Given this list of marker genes PSMB9, PSMA5, CD163, DYNLT1, STAC, GLRX, ATF3, GABRR2, SPTA1, CCL4, PSME2, OVOL2, ATF5, HSPA5, NDUFA9, SLC6A3, KCNJ15, QRICH1, IFIT3, UGDH, ADH5, ALOX5, BTN3A1, ALPI, PARD6B, EMP1, AOPEP, CIR1, ADAM18, NPAS3, NSDHL, VAMP5, MYD88, KIF5A, ACTR3, CLEC2B, NEDD8, BRS3 (NCBI Gene Id 680), HOXB13 (NCBI Gene Id 10481), SLC35B1, LILRB2, FOXI1, GPC4 (NCBI Gene Id 2239), IL7R (NCBI Gene Id 3575), MYO1B, MAFK, LGALS9, HCG9, CYP7A1, HR, CMA1 (NCBI Gene Id 1215), DKK1, BCL2A1, ST3GAL5, EPHX2, LAMA4, LAIR2, IFI35, FCER1G, B4GALT5, SARDH, TRIM10, RBM17, CD6 (CD6 molecule), PFKFB4, CXCL9, ISG20 (interferon stimulated exonuclease gene 20), YLPM1, LHFPL2, YKT6 (YKT6 v-SNARE homolog), MANF, ENPP2, SDC2, LYN, AKT2, UBA7, CAP1, RRH, GLUL, VNN1, ZNF135, GTF2B, CD38, TNFAIP2, STK38L, TXNIP, FOS, CEP170B, ERLIN2, SMURF2, LPAR1, LIPA, FCAR, GJC1 (NCBI Gene Id 10052), KCNJ4, BRSK2, LPIN1, SCARB2, MNDA, CLCNKA, TACR1, FCGR1A, CACNG3, CCL2, FCGR3A, USP6, LCAT, GPR137B, GUCA1B, AVP, CDHR1, APC, ADIPOQ, ZMIZ2, ANXA9, ATP2C1, RSC1A1, HSPA1A, GBP1, BBS9, VWA8, EFNB2, TGFA, BRPF1, LGALS3BP, SSR2, CCL7, SCGB1D2, DUSP6, FABP4, AQP7, CD14, DHH, TGM3, MAPK6, ETV5, RAD54L2, ZNF165, GFAP, ATP1A3, TIMP3, XRCC1, HSPA8, CASP1, PSMA6, UBE2L6, PRDX1 (peroxiredoxin 1), PPBP, CASR, ACRV1, GSTZ1, NCKAP1L, HFE, FKBP1A, S100A8, C3AR1, ZKSCAN1, GCH1, MMP8, TAP1, N4BP2L2-IT2, PPP1R2C, CYP1B1, PTPN2, PNISR, ACSL1, APOL1, TRIM14 (tripartite motif containing 14), ASCL2, NDUFV2, SERPING1, RNF6, VILL, BST2, ALDH3B1, PSMB8, PIR, ANG, GBX2, KCNB1, ARHGAP26, KCTD12, MYL12A, RIBC2, TRIM21, ADGRE5, F3 (coagulation factor III), TSC22D3, RAB5C, CKAP4, LINC01565, IGHA1, TALDO1, MICB (NCBI Gene Id 91956), TUB, ALOX5AP (NCBI Gene Id 241), C1QB, SP100, TNFSF12, here is a description of the gene set: species: Homo sapiens Human Gene Set: GSE360_T_GONDII_VS_M_TUBERCULOSIS_DC_DN from publication Chaussabel D, Semnani RT, McDowell MA, Sacks D, Sher A, Nutman TB (PMID 12663451) Monocyte-derived dendritic cells (DC) and macrophages (MΦ) generated in vitro from the same individual blood donors were exposed to five different pathogens, and gene expression profiles were assessed by microarray analysis. Responses to Mycobacterium tuberculosis and to phylogenetically distinct protozoan (Leishmania major, L. donovani, Toxoplasma gondii) and helminth (Brugia malayi) parasites were examined, each of which produces chronic infections in humans yet vary considerably in the nature of the immune responses they trigger. Genes down-regulated in comparison of dendritic cells (DC) exposed to T. gondii versus DCs exposed to M. tuberculosis.